Given this list of marker genes Ghsr, Ghrl, Ada, Dbn1, Drd2, Ucn, Arrdc3, Trpc2, Cck, Npsr1, Adora1, Esp22, Ins1, Lepr, Fto, Ttc21b, Drd1, Insr, Crhr2, Nmu, Esr2, Retn (NCBI Gene Id 65097), Mecp2, Ptger3, Ceacam2, Ins2, Trh, Mc4r, Npy2r, Napepld, Crhr1, here is a description of the gene set: Mouse Gene Set: GOBP_NEGATIVE_REGULATION_OF_BEHAVIOR Any process that stops, prevents, or reduces the frequency, rate or extent of behavior, the internally coordinated responses (actions or inactions) of whole living organisms (individuals or groups) to internal or external stimuli. studied in species Mus musculus